Given this list of marker genes GRM1, ITPR1, KAT5, RORA, SLC1A6, ATXN1, here is a description of the gene set: studied in species Homo sapiens Pathway Definition from KEGG: ATXN1* -| (RORA+KAT5) => (ITPR1,SLC1A6,GRM1) Human Gene Set: KEGG_MEDICUS_VARIANT_MUTATION_CAUSED_ABERRANT_ATXN1_TO_RORA_MEDIATED_TRANSCRIPTION Mutation-caused aberrant ATXN1 to RORA-mediated transcription. Pathway ID: N00966. Pathway type: Variant. Pathway class: nt06462 Spinocerebellar ataxia.